Given this list of marker genes SEMA3E (NCBI Gene Id 9723), EDNRA, NRP1, RPS7, PHOX2B, ISL1, EDN1, NOLC1, SOX9, NRP2, ARB2A, KITLG, SNAI2, MAPK3, JAG1, RET, SFRP1, KBTBD8, SEMA6B, FOXC1 (NCBI Gene Id 3666), EDNRB, SEMA5A, HES1, LAMA5, NRG1, GBX2, SEMA7A, ERBB4, SOX8, CORO1C, TWIST1, OTUD5, WNT8A, SEMA6C, CDC42, SMAD4, PITX2, TCOF1, SMO (NCBI Gene Id 6608), NRTN, ZEB2, GSC, BMP7, SEMA3B, PDCD6, SEMA4B, SEMA4D, HAND2, KLHL12, FOLR1, CITED2, FOXC2, CYP26C1, SHH, TBX1, ACVR1, SEMA3D, FN1, RDH10, LRP6, MEF2C, TAPT1, SEMA4G, PEF1, EDN3, CFL1, BMPR1A, SEMA6A, SEMA6D, SEMA3A, EFNB1, ALDH1A2, MAPK1, OVOL2, SEMA3F, EXT1, SEMA4C, SEMA4F, WNT10A, CDH2, BMP4, SEMA4A, SEMA5B, FBXL17, GDNF, PHACTR4, FRZB, SEMA3C, SIX1, ENG, FGF19, RADIL, HIF1A, HTR2B, SOX10, SEMA3G, here is a description of the gene set: The process in which a relatively unspecialized cell acquires specialized features of a neural crest cell. Human Gene Set: GOBP_NEURAL_CREST_CELL_DIFFERENTIATION species: Homo sapiens